Given this list of marker genes MAJIN, SPDYA, TERB1, SUN1, TERB2, here is a description of the gene set: Human Gene Set: GOBP_MEIOTIC_ATTACHMENT_OF_TELOMERE_TO_NUCLEAR_ENVELOPE studied in species Homo sapiens The meiotic cell cycle process in which physical connections are formed between telomeric heterochromatin and the nuclear envelope, facilitating bouquet formation.